Given this list of marker genes Gng3, Gng4, Gria1, Gng13, F2r, Cct5, Gng12, Rasd2, Dynlt1b, Gng14, Rgs11, Gnas, Gng5c, Gng2, Gng5, Gng10, F2rl1, Gng7, Rgs7, Gng11, Rasd1, Gngt1, Gngt2, Oprm1, Gng8, here is a description of the gene set: studied in species Mus musculus Mouse Gene Set: GOMF_G_PROTEIN_BETA_SUBUNIT_BINDING Binding to a G-protein beta subunit.